Given this list of marker genes ZFYVE1, PAQR9, MPRIP, PIP4P1, HIBADH, SH3TC2, NUDCD3, TMEM35A (NCBI Gene Id 59353), KDM4E, CAND2, SPRYD3, PPP1R12B, UQCC1, PLXNC1, SERBP1, EPB41, JUP, LALBA, E2F2, OPCML, TMEM8B, SPRY3, STK24, PDYN, MAPK8IP3, VANGL2, THBS1, AKAP8, FMOD, GMFB (NCBI Gene Id 2764), PCDH1, RAD51D, NOL7, HS3ST3A1, NBL1, SLF1, PLXNA4, PTPN7, RIMS3, PRKCA (protein kinase C alpha), PPP3R1, TRIM27, SLC22A23, CASTOR2, MYEOV, MICAL2, ARHGAP23, ZNF862, LASP1, DAB2IP, PPM1F, UGT2B15, RIMKLA, SRGAP2, ZCCHC14, HECTD4, SARM1, FAM3C, XIRP1, RAB43, ZNF395, RHOBTB1, LRP3, COL5A3, SHANK2, MLEC, SERPIND1, NFAM1, RAB3D, SLC23A2, NRP2, KLF7, UBTF, DDC, NBN, LRRFIP1, EIF2S1 (eukaryotic translation initiation factor 2 subunit alpha), MGA, PCDHB3, SDK2, ACSL1, KAT6A, TMEM164, RTKN2, CALU, IGFBPL1 (NCBI Gene Id 347252), ACTR2, NIPBL, UBASH3B, RNF183, MINDY2, CPSF2, MDGA1 (NCBI Gene Id 57164), PPM1H, CAMKK1, KCTD17, HAS3, SRCAP, EMSY, BUD23, TRIM67, WNT4, IL18BP, TRABD2B, MAP9, PRDX3, MYOCD, IMP3 (IMP U3 small nucleolar ribonucleoprotein 3), NUDT2, LIMS2, CST3, FZD7, RIN1, PDCD4, SLC38A7, MINK1, PAPPA, GTF2H5, POLH, P2RY2, ITGB1, LZTS1, C1QTNF6, ATG16L1 (NCBI Gene Id 81560), CDR2L, CWC25 (NCBI Gene Id 54883), ATRN, APBA1, KCNK13, NT5C3B, TMEM229B, RASAL2, TRA2B, UBE3B, DESI1, ACAN, KLHL29, SLC35E1, SBF2, EHF, PPME1, ITGA5, here is a description of the gene set: species: Homo sapiens Human Gene Set: MIR4308 from publication Chen Y, Wang X (PMID 31504780) Genes predicted to be targets of miRBase v22 microRNA hsa-miR-4308 in miRDB v6.0 with MirTarget v4 prediction scores > 80 (high confidence targets).